The following is a description of a gene set: Catalysis of an oxidation-reduction (redox) reaction in which an aldehyde or ketone (oxo) group acts as a hydrogen or electron donor and reduces a hydrogen or electron acceptor. studied in species Mus musculus Mouse Gene Set: GOMF_OXIDOREDUCTASE_ACTIVITY_ACTING_ON_THE_ALDEHYDE_OR_OXO_GROUP_OF_DONORS, and this is the list of marker genes: Aldh4a1, Aldh7a1, Akr1b1, Akr1c21, Akr1cl (aldo-keto reductase family 1, member C-like), Dlat, Aldh6a1, Aldh1l2, Pdhx, Dbt, Dhtkd1, Aldh1a3, Akr1c14, Akr1c18, Pdhb, Aldh5a1, Aldh18a1, Far2, Dld, Akr1c12, Aldh16a1, Ogdh, Aldh3b1, Aldh3b2, Rdh11, Aldh3a2, Aldh3b3, Gapdhrt2, Aldh1b1, Suclg2 (succinate-Coenzyme A ligase, GDP-forming, beta subunit), Akr1c20, Akr1b10, Aldh1a7, Htatip2, Dhrs4, Pdha2, Akr1b7, Aox2, Aldh1l1, Aox3, Aldh1a2, Bckdhb, Akr1c19, Aldh1a1, Gapdhrt, Hao1, Fmo5, Far1, Aldh8a1, Akr1b8, Akr1c6, Bckdha, Gapdhs, Ogdhl, Aldh2, Aldh3a1, Aox4, Aox1, Gapdh, Adh4, Adh7, Aldh9a1, Adh5, Pdha1, Akr1c13